The following is a description of a gene set: Catalysis of the reaction: acyl-CoA + 1,2-diacylglycerol = CoA + triacylglycerol. species: Mus musculus Mouse Gene Set: GOMF_DIACYLGLYCEROL_O_ACYLTRANSFERASE_ACTIVITY, and this is the list of marker genes: Mogat2, Dgat1, Dgat2l6, Dgat2, Mogat1, Awat2